Given this list of marker genes RNF19A, ANKLE2, BACH2, TMEM86A, RRAGD, MICU1, PSEN1, VPS26C, FANCD2, OSBPL3, SYK, IDS, APOBEC1, USP15, PLCB2, SELENOP, IL18, PLEKHM3, NFIC, DGLUCY, SNX13, GMNN, PPP1R12B, IKBIP, FABP7, KANSL1, SYT11, SLC30A1, SHTN1, ITPR2, PFKFB3, PRXL2B, TNKS, RNF167, AMOT, SCLY, RNH1, TLL1, GPR162, CEP15, DEPTOR, CYFIP2, MEGF9, ARHGEF1, MSH3, CAMK1D, GTF2I, STARD5, ARHGAP18, TP53INP2, CENPN, RGL2, DPYSL2, MON1A, PLPP3, KLHL6, LIPA, SH2D3C, CD1D, NAGA, BORCS6, PPM1H, WDR7, KIF13B, DOCK5, GGA1, C4orf46, RBL1, TMEM38B (NCBI Gene Id 55151), EEF2, SASH1, SGSH, PTDSS2, MAN1C1, LPXN (NCBI Gene Id 9404), MGLL, PAK1, HACL1, POGLUT3, ZDHHC14, KCTD21, RAMP1, RBBP9, ATG7, PRPS2, BEX1, RMND5A, TPRA1, TIFA, ITGA6, NIPAL3, PHF8, PTPRF, GGA2, GAS6, FANCG, KIFBP, PMP22 (peripheral myelin protein 22), PPT2, GPR65, DENND4C, ECHS1, TSSK2, SPIC, ZNF512, PRRG1, MAMDC2, CC2D2A, DBNDD2, MPP1, DNAJC30, GTF2A1, HPGD, LYST, ZNF746, LPCAT2, GPR68, TEP1, SLC6A8, HADHB, MFGE8, OPHN1, XDH, NACC2, IMPA2, GALK2, GALNT4, ATP8B4, TMCC3, NUSAP1, RAP2B, KMT2A, RELA, EDEM3, EYA3, RB1CC1, PLD3, MTMR10, PNPLA7 (NCBI Gene Id 92716), SLC12A6, PPOX, TMEM230, STRIP2, KIAA0930, SORL1, ATOSB, RASSF2, SCPEP1, INPP4A, TM2D2 (NCBI Gene Id 83877), IL7R, ZMYND15, CACUL1, ABCB7, TMCC1, ARL5A, RAB8B, GPS2, RASA4, FMO5, DCAF8, ZFP91, ZC3H6, PIGS, RBBP4, DCTN5, ALOX5AP, GPR155, C6orf62, MAN2B1, IQGAP2, BCKDK, KIAA0319L, ZBTB4, TSPAN14, PARP16, NAT9, AURKA, TECPR2, TFEB, PIP4K2A, CDHR1, MYLIP, BNIP3L, RMND1, CIC, ATP6V0D2, PLXNA2, PLPP6, KCNK13, MTURN, BAMBI, SDHAF4, TUSC1, ABHD4, ZNF839, C2CD5, GSN, MAVS, NUDT16, here is a description of the gene set: Human Gene Set: GSE26343_WT_VS_NFAT5_KO_MACROPHAGE_LPS_STIM_DN studied in species Homo sapiens from publication Buxadé M, Lunazzi G, Minguillón J, Iborra S, Berga-Bolaños R, Del Val M, Aramburu J, López-Rodríguez C (PMID 22312110) Gene expression from WT and NFAT5 KO primary macrophage cultures. Genes down-regulated in bone marrow-derived macrophages stimulated with LPS: wildtype versus NFAT5 knockout.